The following is a description of a gene set: species: Homo sapiens Excessive growth or abnormal thickening of bone tissue. Hyperostosis Human Gene Set: HP_HYPEROSTOSIS, and this is the list of marker genes: PHEX, LEMD3, ERCC2 (NCBI Gene Id 7269), ERCC4, MAN2B1, FGFR1 (NCBI Gene Id 84151), SLC29A3, IDUA, XPA, HNRNPA1, VCP, TNFSF11 (NCBI Gene Id 8600), LRP5, WIPF1, KRAS, GNAQ, COL1A1, HNRNPA2B1, LRP4, THOC2, GNAS, NOTCH3 (NCBI Gene Id 791), SMAD4, SLC39A14, CA2, MAP2K1, RPS6KA3, ERCC3, PTDSS1, GJA1, AKT1, TNFRSF11A, SLCO2A1, TCIRG1, TGFB1, ERCC5, GALNT3, TNFRSF11B, PRKAR1A, TBXAS1, XPC, DDB2, SOST, FLNA, AMER1, WAS, ALMS1, ANKH, OSTM1, SP7, PTEN, COX4I2, PIK3CA